Given this list of marker genes METTL25B, TFB2M, TFB1M, ZCCHC4, DIMT1 (NCBI Gene Id 27292), TRMT61B, METTL5, here is a description of the gene set: Human Gene Set: GOMF_RRNA_ADENINE_METHYLTRANSFERASE_ACTIVITY Catalysis of the reaction: S-adenosyl-L-methionine + rRNA = S-adenosyl-L-homocysteine + rRNA containing methyladenine. species: Homo sapiens